Given this list of marker genes RAD18, VCP, SKIC8, RNF152, SELENOS, PAF1, H2BC3, LEO1, H2BC4, H2BC17, UBE2L3, PEX2, RRAGA, WAC, H2BC14, RNF40, UBE2J2, BCL10, H2BC13, PEX10, H2BC8, PEX14, RTF1, UBE2N, PCNA, H2BC11, H2BC10, RNF144A, CDC73, RNF181, TMEM129, UBE2D2, UBB, SHPRH, H2BC12, DERL1, HLA-A, PEX5, UBA52, H2BC6, PRKDC, PEX12, CTR9, RPS27A, H2BC5, PEX13, RNF20 (NCBI Gene Id 56254), UBE2B, UBC, H2BC15, HLTF, UBE2A, UBE2V2, UBE2D3, H2BC9, H2BC7, H2BC1, UBE2D1, UBE2E1, here is a description of the gene set: E3 ubiquitin ligases ubiquitinate target proteins Human Gene Set: REACTOME_E3_UBIQUITIN_LIGASES_UBIQUITINATE_TARGET_PROTEINS species: Homo sapiens